Given this list of marker genes TXNRD1, TIMM8B, LSM4, CDK1, GTF3C5, INVS, RPL26L1, PSMD11, SNRPE, RAB33A, MYH1, BRD4, CKS1B, DCTPP1 (dCTP pyrophosphatase 1), PLA2G4A, SEH1L, MARCKSL1, CAPRIN1, H2AZ1, RASIP1, AAMP (angio associated migratory cell protein), CTPS1, NFE2L3, SLC7A5, RAN, ITGAE, GOLT1B, TBL1X, H1-0, PEX3, SDC4, LAMTOR2, PTGS2, CCNA2, MPST, GGH, MYH10, USP22, BORA, NFU1, POLD1, HIRA (histone cell cycle regulator), UQCRFS1, RRM2, GSPT2, PRIM1, NCAPG2, WBP4, PIP5K1B, TDP1, GABPB1, FUT8, TACC3, CLNS1A, MRPL12, MCM5, PRPS2, CDKN3, COL6A3, NDUFA4, ACY1, VBP1, SGCG (sarcoglycan gamma), SLC2A3, ATG101, FH (NCBI Gene Id 83748), CLIC4, ZNF410, EGR1, HSD17B12, METTL13 (NCBI Gene Id 88158), MYH6, PPP1R2, KDELR2, CENPA, H2BC9, STAP1, NRBF2, ACSL1, PRDX3, ELAVL1, TUBB, TAF10, TIGAR, EFR3B, MED21, PPIF, U2AF2, AGK, RAB11FIP1, KIF20B, PA2G4, SPDL1 (spindle apparatus coiled-coil protein 1), RNASEH2A, EFCAB11, CERS4, SEC23B, FRMD4B, DAPK1, RRM1, ECHS1, GNA15, TRMT1L, ADIPOR1, SFPQ, ENO1, BDH1, TP53, CD226, POLR1G, ACOT7, PRMT7, RBM14, UNG, RTCB, TFB2M, ASNSD1, LAP3, GINS2, KIF15, MCTS1, PSMA2, SLC39A14, CDC27, PFDN4, KIF14, CDC25C, NCBP1, ADM, NDUFA6, CAB39, TOP2A, NDUFC1, TIMELESS, BLM, MED20, MTFR1, PCTP, KIF23, FILIP1L, DCTN6, OARD1, MRPL11, ALDH3A2, CDC42BPA, PSMB5, THRAP3, BAG2 (NCBI Gene Id 9532), RRP7A, FADS1, MAIP1, SOD1, PHYH, CCL1, C1QBP, NDUFS4, NUP133, MICAL2, STIMATE, MRPS33, LUC7L2, OIP5, NUP37, HNRNPM, ETHE1, TUBB6, RAD54L, ORC6, DDX18, RYBP, BCAR3, TYMS, FKBP1A (NCBI Gene Id 2280), PRDM10, CD200, TIPIN, GMDS, HBEGF, CKS2, TRMT112, DBI, EHHADH, GLRX2, LRRC41, PDIA4, MRPL3, IFT56, LAMTOR3, CSE1L, PLK1, TMEM214, MYB, TKT, ETFA, PLAGL1, NME7, MRPL40, CYC1, SDHB, RIBC2, here is a description of the gene set: In the present study we used Affymetrix oligonucleotide microarrays to produce gene transcription profiles for the major leukocyte types in humans. This comprehensive dataset enabled us to not only establish which genes were expressed in each leukocyte type, but also which genes were expressed in each subset after activation. The used of a comprehensive dataset of gene profiles from all the major human leukocyte subsets enabled a novel and powerful means for identification of genes associated with single leukocyte subsets, or different immune paradigms. species: Homo sapiens Genes down-regulated in comparison of effective memory CD4 T cells versus Th2 cells. from publication Jeffrey KL, Brummer T, Rolph MS, Liu SM, Callejas NA, Grumont RJ, Gillieron C, Mackay F, Grey S, Camps M, Rommel C, Gerondakis SD, Mackay CR (PMID 16474395) Human Gene Set: GSE3982_EFF_MEMORY_CD4_TCELL_VS_TH2_DN